Given this list of marker genes TUBA1C (NCBI Gene Id 84790), TUBB4A, TUBA3D, SPAST, TUBB6, TUBB4B (NCBI Gene Id 10383), TUBA3C, TUBA4B (tubulin alpha 4b), IST1, CHMP6, CHMP2A, VPS4A, TUBB8, TUBA3E, CHMP2B (NCBI Gene Id 7877), TUBB8B, TUBA4A, TUBB1, CHMP4B, LEMD2, CHMP7, TUBA1A, TUBA8, TUBB2A, TUBB2B, CHMP4C, CHMP3, TUBB3, CC2D1B, CHMP4A, TUBAL3, TUBA1B, here is a description of the gene set: Human Gene Set: REACTOME_SEALING_OF_THE_NUCLEAR_ENVELOPE_NE_BY_ESCRT_III Sealing of the nuclear envelope (NE) by ESCRT-III species: Homo sapiens